The following is a description of a gene set: Binding to S-adenosyl-L-methionine. Human Gene Set: GOMF_S_ADENOSYL_L_METHIONINE_BINDING species: Homo sapiens, and this is the list of marker genes: TPMT, SUV39H2, N6AMT1, TSR3, PCIF1, CBS, KMT5B, PRMT1, SPOUT1, METTL5, KMT5C, METTL17, FTSJ1, METTL14, METTL3, ZCCHC4 (zinc finger CCHC-type containing 4), SAMTOR, TFB1M, MOCS1, PRMT8, GNMT, ENSG00000274276, SETD6